The following is a description of a gene set: studied in species Mus musculus from publication Tabula Muris Consortium (PMID 32669714) Mouse Gene Set: TABULA_MURIS_SENIS_LIVER_ENDOTHELIAL_CELL_OF_HEPATIC_SINUSOID_AGEING, and this is the list of marker genes: Rpl21, Pdap1, Hspb1, Nfib (nuclear factor I/B), Rpl7 (ribosomal protein L7), Hes1, Zbtb4, Rps7, Rbp1, Rps15, Rpl9, Irf1 (NCBI Gene Id 16362), Nucks1, Pfdn5, Mia2, Zbp1, Iqgap1, Nap1l1, Rps8, Tpr, Tardbp, Rassf3, Smpdl3a, Mycbp2 (NCBI Gene Id 97940), Rps3, Tsn, Hamp, Rpl38, Rock2, Cox7a2l, Tcf7l2, 2410006H16Rik, Rps23, Pin4, Psme1, Mgst1, Rplp2, Slfn5, Rplp1, Pard3b, Zfas1, Gm6654, Cdc42ep3, Rps4x, Rps11, Actr2, Iigp1, H2-Q4, Rac2, Ryk, H2-Aa, Psmb8, Rps5, Tnfaip2, Ier3 (NCBI Gene Id 15937), AU021092, Ndufs5-ps, Nfe2l1, Cd74, Aimp1, Gm7609, Pink1, Mier1, Arhgef12, Tpd52 (tumor protein D52), Gngt2, Rpl19, Cdc42ep1, Rpl23 (ribosomal protein L23), Dusp3, Sod1, Eif4b, Rps15a-ps6, Lpl (lipoprotein lipase), Crk, Wnk1, Sptbn1, Rps20, Insig1, Clec4n, Prrc2b, B2m, Timp3, Spi1 (NCBI Gene Id 20375), Car8, Ece1, Hnrnpm, Adgrg1, Rps10, Set, Rps14, Rpl18a, Ralbp1, Depp1 (DEPP1 autophagy regulator), Jcad (junctional cadherin 5 associated), Brd2, H2-K1, Akr1a1, Tspo, Rpl39, Ubl3, Mndal, Chd4, Tmem176b, Ndufa1, Ptpn12, Hmg20b, Msrb3, Cavin1, H2-T23, Rpl23a, Gm6402, Rarg, Rpl35a, Isg15, Klhl5, Chmp3, Csf2ra, Tor1aip1, Tacc1, Smad6, Mir703, Zfp36l1, Znfx1, Rpl13, Slu7, Mafb, Pltp, Nfic, Sox18, Nsa2, Zfp36l2, Oaz1, Psmb9, Smim27, Rpl13a, Brd9, Selenow, Axl, Rnaset2b, Csde1, Rps17, Txnip, Phf20l1, Wbp4, Rpl27a (ribosomal protein L27A), Rps27, Nceh1, Tmem140, Kdm2a, Eif3f, Rsad2, Arid4a, Rpl14, Lpp, Epb41l2, Ifit3, Clec12a, Rpl36, Swi5, Hp1bp3, Dse, Sdc3, Cflar, Ehd4, Bvht (NCBI Gene Id 545261), Prrc2c, Rpl31, Actn4, Zeb1, Dnajc8, Gbp4, Hid1, Pcnp, Rpl36a, Tut4, Bod1l, Hipk1, Ldhb, Cd84, Sh3bp5, Id4, AW112010, H2-Eb1, Spop, Ptpn18, Rpl34-ps1, Pnpla8, Samhd1, B4galt1, Snrnp27, Cmip, Luc7l2, Prdx5, Rpl10, Rack1, Cyp26b1, Sfxn1, H2az2, Smim11, H2-DMb1, Ap2a2, Fau, Crip1, Ccl4, Bzw1, Eef1a1, Csprs, Elf1, Rpl35, Anp32b, Trim12c, Eef2, 1810037I17Rik, Rbm8a, Frg1, Sptan1, Irf7, Tcf25, Nr3c1, Sel1l, Ubb-ps, Ces2g, Atp5me, Mapk3, Crim1, Vat1, Wipf1, Eef1b2 (NCBI Gene Id 80613), Rps13, Rock1, Prelp, Wbp2, Serpinb6a, Cox20, Rpl3, Gm6222, Cenpb, Psmb10, Cltb, Nedd4, Pafah1b1, Ik, Tmsb4x, Gm9320, Nudcd3, Rpsa, Eif3h, Tmem176a, Hmox1, Nfia (NCBI Gene Id 68838), Cbx3, Nipsnap2, Lgals1, Pkn2, Lrp6 (low density lipoprotein receptor-related protein 6), Rxra, Rpl31-ps12, Gas5, Rpl32, Rps6, Ralgps2, Rab13, Arf3 (ADP-ribosylation factor 3), Hnrnpc, Rps3a1, Bcl2a1b, Ccl5, Apoc2, Esm1, Use1, Flywch1, Gabarapl1, Oaz2, Amotl2, Prr13, Oip5os1, Rps9, Rps15a, Rps28, Prpf4b, Myl12b, Slx1b, Rps15a-ps4, Vcam1, Acta2, Bgn, Tmsb10, Rps19, Id2, Rpl22l1, Hcls1, Pabpc1, Hspd1 (heat shock protein 1 (chaperonin)), Morf4l1-ps1 (mortality factor 4 like 1, pseudogene 1), Snhg8, Ensa, Cdkn1c, Ctdsp2, Ctnnb1, Fcho2, Fam32a, Sqstm1, Hnrnpa0, Ktn1, Scn1b, Rps21, Pfdn1, Sertad2, Sec62, Capg, Stat1, Rpl17, Hnrnpul2 (heterogeneous nuclear ribonucleoprotein U-like 2), Dennd5a, Dazap2, Xpc, Il1b, Rpl22, Plekho2, Plaat3, Rps27a, Fam124a, Sumo3, Mitd1, Csf1, Klf10, Ap2b1, Alkbh5, Aldh2 (aldehyde dehydrogenase 2, mitochondrial), Ndufa7, Pgd, Dock6, Cbfa2t3, Rgs2, Atp5mc3, Churc1, Gstp1, Rbm3, Sh3tc1, Mrps21, Rps29, Ms4a6c, Ddx6, Ncl, Wdr89, Gnb1, Fads1, Dync1i2, Rps18, Map4, Cd82, Zeb2, Macf1, Rpl37, Bnip2, Tnfrsf1b, Ly6a, Nop53, Ddx18, Cyb5r3, Nol7, H2-Ab1, Gigyf1, Ndufa5, Taldo1, Slc40a1, Rpl34, Cxcl9 (C-X-C motif chemokine ligand 9), Phactr2, Rpl5, Rps12, Arap3, Rpl32l, Snrnp70, Gstm2, Rps24, Rpl12, Dnase1l3, Dtx3l, Sp100, Rpl28, Psap, Tmem250, Junb, Rpl37a, Ptma, Gm15421, Rpl4, Zfp503 (zinc finger protein 503), Sh3bgrl, Rgs3, Norad, Ywhaz, Rps25, Bola2, Atrx, Brd3, Gbp7, Rpl6 (NCBI Gene Id 19988), Ptp4a2, Tpt1, Pbrm1, Lmo4, Lst1, Comt, Clec2d, Slpi, Lbh, Rtf1